The following is a description of a gene set: Downbeat nystagmus species: Homo sapiens Downbeat nystagmus is a type of fixation nystagmus with the fast phase beating in a downward direction. It generally increases when looking to the side and down and when lying prone. Human Gene Set: HP_DOWNBEAT_NYSTAGMUS, and this is the list of marker genes: ANO10, PLA2G6, RFC1, FAT2, FGF14, COQ2, CACNA1A